The following is a description of a gene set: part of: Antimicrobial mechanism of IFN-stimulated genes This event has been computationally inferred from an event that has been demonstrated in another species.<p>The inference is based on the homology mapping from PANTHER. Briefly, reactions for which all involved PhysicalEntities (in input, output and catalyst) have a mapped orthologue/paralogue (for complexes at least 75% of components must have a mapping) are inferred to the other species. Reactome Pathway: PKR-mediated signaling electronically inferred by orthology from the curated human pathway species: Mus musculus, and this is the list of marker genes: Ilf3, Tubb6, Tuba3b, Hspa1l, Map2k6, Ppp2r1b, Ptpn2, Cenps, Trp53, Tubal3, Tuba1a, Tuba8, Fancc, Faap100, Ppp2r5a, Cenpx, Mavs, Cdk1, Mapt, Tuba1c, Ikbkb, Tuba1b, Faap20, Npm1, Hspa2, Fance, Tubb4a, Ilf2, Arih1, Snca, Tuba4a, Tarbp2, Tubb2b, Dus2, Fancb, Tubb4b, Fancg